The following is a description of a gene set: from publication Mootha VK, Lindgren CM, Eriksson KF, Subramanian A, Sihag S, Lehar J, Puigserver P, Carlsson E, Ridderstråle M, Laurila E, Houstis N, Daly MJ, Patterson N, Mesirov JP, Golub TR, Tamayo P, Spiegelman B, Lander ES, Hirschhorn JN, Altshuler D, Groop LC (PMID 12808457) studied in species Homo sapiens Tricarboxylic acid related genes; based on literature and sequence annotation resources and converted to Affymetrix HG-U133A probe sets. DNA microarrays can be used to identify gene expression changes characteristic of human disease. This is challenging, however, when relevant differences are subtle at the level of individual genes. We introduce an analytical strategy, Gene Set Enrichment Analysis, designed to detect modest but coordinate changes in the expression of groups of functionally related genes. Using this approach, we identify a set of genes involved in oxidative phosphorylation whose expression is coordinately decreased in human diabetic muscle. Expression of these genes is high at sites of insulin-mediated glucose disposal, activated by PGC-1alpha and correlated with total-body aerobic capacity. Our results associate this gene set with clinically important variation in human metabolism and illustrate the value of pathway relationships in the analysis of genomic profiling experiments. Human Gene Set: MOOTHA_TCA, and this is the list of marker genes: SUCLG1, IDH3B, SDHC, SDHB, SDHD, FH, SUCLA2, SDHA (NCBI Gene Id 6389), OGDH, CS, RPL18AP16, ACO2, IDH3G, IDH3A, IDH2, MDH2 (malate dehydrogenase 2)